Given this list of marker genes CAMK2A, PIK3R1, DLG4, ANGPT1, FNTA, BRAP, FGF9, IL2RG, RAP1B, PSMB5, PPP2R5D, BCL2L1, NRG1, ICMT, LYPLA1, MAP3K11, SPTBN1, MAP2K1, DUSP8, PSMA2, DUSP9, CSK (C-terminal Src kinase), PPP2R1A, FRS3, RPS27A, PDE6D, RASA1, SHOC2, UBB, NCAM1, IRS2, SPRED2, PDGFRB, SYNGAP1, MET, PPP2R5A (protein phosphatase 2 regulatory subunit B'alpha), IQGAP1, ABHD17B, IL17RD, LAMTOR3, RGL3, KIT, JAK1, PPP1CC, VCL, PPP2R5B, ITGB3, PPP2R5E, EPGN, FGF20 (NCBI Gene Id 26281), PSMD7, PRKG2, PDGFB, KSR2, NF1, FGA, DUSP16, EGF, DLG1, DUSP7, FGF23, FGF19, PIK3CA, MARK3, FGF6, PSMD2, PEA15, DLG2, PSMB4, GRB2, FGFR4, RASAL1, BTC, IL3RA, PAQR3, RALGDS, RGL2, SHC2, KBTBD7, FGFR3, PPP2R1B, FGF4, PPP5C, RASGRP4, CALM1, ABHD17A, RASGRF2, PPP2CB, PPP2R5C, DUSP6, KITLG, FRS2, FGF22, IL3, PTPRA, NRTN, HRAS, VWF, PSMA3, SHC1, DLG3, PSMC1, RASA2, RBX1, RANBP9 (NCBI Gene Id 10048), RASA3, SPTBN2, SPTA1, ERBB3, EREG, PDGFRA, SPRED1, ARTN, SEM1, JAK3, FGF17, FGF2, RASAL2, DUSP1, RASAL3, PSMD14, IL2RA, ACTG1, MAP2K2, APBB1IP, FGB, IL5, UBC, TLN1, NRG2, PSPN, FGG, PTK2, WDR83, DUSP10, UBA52 (NCBI Gene Id 7311), FLT3LG, DUSP4, PSMA7, CSF2, LAMTOR2, PSMD12, PSMD13, GRIN2D, LAT, FN1, CNKSR2, DAB2IP, NRG4, FGF18, PTPN7, LRRC7, GRIN2B, PSMA5 (NCBI Gene Id 5686), KRAS, GFRA4, PSMC4, CAMK2D, MAPK3, ACTB, BRAF, USP17L2, GOLGA7, PSMA6, GFRA2, CUL3, RASGRF1, JAK2, CAMK2G, PSMB7, GFRA1, MAPK12, IRS1, IL2RB, PEBP1, TEK, MAPK1, PSMC3, RASGEF1A, AREG, RASGRP3, RCE1, SPTB, SPTAN1, PDGFA, PTPN3, FGF16, FGFR2, FGF1, ZDHHC9, FLT3, PHB1, DUSP2, PSMA4, ERBB4, SPTBN5, FGFR1, FNTB, ARRB2, HGF, PSMB6, SHC3, PSMB3, SOS1, FYN, PSMD11, EGFR, PSMD6, PSMC6, IL5RA, PPP2CA, SPTBN4, PSMC2, ADRM1, SPRED3, ARAF, RASGRP1, ERBB2, ACTN2, NRAS, ABHD17C, RGL1, GDNF, PIK3R2, PSMB1, IL2, KLB, PSMD1, SRC, CSF2RA (colony stimulating factor 2 receptor subunit alpha), PSMA1, PRKCQ, PPP1CB (NCBI Gene Id 5500), FGF5, ARRB1, ARL2, ITGA2B, FGF8, PSMC5, NEFL, PSMD8, PSMB2, FGF10, PIK3CB, GFRA3, HBEGF, YWHAB, CSF2RB, FGF3, TGFA, KSR1, MRAS, NRG3 (neuregulin 3), FGF7, CNKSR1, RET, RAF1, RAPGEF2, CAMK2B, PSMD3, DUSP5, RAP1A, KL, GRIN1, RASA4, here is a description of the gene set: Reactome Pathway: RAF/MAP kinase cascade part of: MAPK1/MAPK3 signaling The RAS-RAF-MEK-ERK pathway regulates processes such as proliferation, differentiation, survival, senescence and cell motility in response to growth factors, hormones and cytokines, among others. Binding of these stimuli to receptors in the plasma membrane promotes the GEF-mediated activation of RAS at the plasma membrane and initiates the three-tiered kinase cascade of the conventional MAPK cascades. GTP-bound RAS recruits RAF (the MAPK kinase kinase), and promotes its dimerization and activation. Activated RAF phosphorylates the MAPK kinase proteins MEK1 and MEK2 (also known as MAP2K1 and MAP2K2), which in turn phophorylate the proline-directed kinases ERK1 and 2 (also known as MAPK3 and MAPK1). Activated ERK proteins may undergo dimerization and have identified targets in both the nucleus and the cytosol; consistent with this, a proportion of activated ERK protein relocalizes to the nucleus in response to stimuli. Although initially seen as a linear cascade originating at the plasma membrane and culminating in the nucleus, the RAS/RAF MAPK cascade is now also known to be activated from various intracellular location. Temporal and spatial specificity of the cascade is achieved in part through the interaction of pathway components with numerous scaffolding proteins. <br> The importance of the RAS/RAF MAPK cascade is highlighted by the fact that components of this pathway are mutated with high frequency in a large number of human cancers. Activating mutations in RAS are found in approximately one third of human cancers, while ~8% of tumors express an activated form of BRAF. species: Homo sapiens